Given this list of marker genes Tubb2b, Tuba1a, Tuba4a, Tuba1b, Tubb4b, Gja1, Tubb6, Tuba8, Tubal3, Tubb4a, Tuba1c, Tuba3b, here is a description of the gene set: part of: Transport of connexons to the plasma membrane electronically inferred by orthology from the curated human pathway Reactome Pathway: Microtubule-dependent trafficking of connexons from Golgi to the plasma membrane This event has been computationally inferred from an event that has been demonstrated in another species.<p>The inference is based on the homology mapping from PANTHER. Briefly, reactions for which all involved PhysicalEntities (in input, output and catalyst) have a mapped orthologue/paralogue (for complexes at least 75% of components must have a mapping) are inferred to the other species. studied in species Mus musculus